The following is a description of a gene set: Photosensitive tonic-clonic seizure studied in species Homo sapiens Generalized-onset tonic-clonic seizures that are provoked by flashing or flickering light. Human Gene Set: HP_PHOTOSENSITIVE_TONIC_CLONIC_SEIZURE, and this is the list of marker genes: CLCN2, KCNQ3, GABRA1, SCN1A, JRK, SCN2A, GABRG2, SCN1B, GABRD, CACNB4, EFHC1, CILK1, PCDH19, SCN9A, SLC9A6